The following is a description of a gene set: species: Homo sapiens Enables the directed movement of azoles, heterocyclic compound found in many biologically important substances, from one side of a membrane to the other. Human Gene Set: GOMF_AZOLE_TRANSMEMBRANE_TRANSPORTER_ACTIVITY, and this is the list of marker genes: SLC28A1, SLC7A1, SLC19A2, SLC15A4, SLC25A19, SLC28A2, SLC66A1, SLC22A2, SLC47A1, SLC38A3, SLC19A3, SLC22A1, SLC38A5, SLC44A4